The following is a description of a gene set: studied in species Homo sapiens Spontaneous, recurrent epistaxis Human Gene Set: HP_SPONTANEOUS_RECURRENT_EPISTAXIS, and this is the list of marker genes: SRC, TPM4, LYST, PTPRJ, GP1BB, MYH9, HPS3 (NCBI Gene Id 85393), GBA1, ENG, ACVRL1, GP9, ITGB3, GP1BA, GDF2, ITGA2B, SMAD4, GNE